Given this list of marker genes CCND2, DYNLT1, SRSF2, MTHFD2, FUS, MTCH2, FES, ZBTB32, DNAJC12, RNF144A, IFNG, ARL15, FOSL1, SLC39A14, PSMD5, CDC25A, PA2G4, KARS1, AHSA1, ACACA, GMPPB, HSPA8, PTRH2, SLC25A44, RNLS, PTPN1, IL18R1, PLVAP, ASB7, STRAP, PHLPP2, PDCL, PRF1, CFLAR, IL18RAP, PKNOX1, NOP10, GRPEL1, LIF, PDIA5, IL2RA, PRKX, TMEM70, PIM1, TRAFD1, STIP1, IRF8, PMCH, EGFL6, IGFBP7 (NCBI Gene Id 3490), SLC30A10, RRAS2, TMEM39A, CHSY1, DDX39B, SEC24D, MANF, NIPA2, ACVR1, EIF1, HDAC4, UBE2L3, EIF2B1, TOMM40, FUBP1, FURIN, SLC35F5, PFDN2, RMC1, SNCA, USP6NL (NCBI Gene Id 9712), UTP14A, TNF, B4GALT2, POLE3, SATB1, TBX21, PGS1 (NCBI Gene Id 9489), MYD88, PRNP, ATP2A2, CSRNP2, TPM4, RAB11FIP1 (RAB11 family interacting protein 1), P2RX5 (NCBI Gene Id 5026), IL15RA, CD53, VCL, GNE, GZMB, BATF, RAB29, FUBP3, SNRPG, PKM, HSPA5, NOP14, AK4, NSD3, PNO1, NUCB1, WARS1, KDSR, MTMR1, AK2, VPS37B, UCK2, MAGOHB, MMD, UBE3C, FRMD4B, ZNF207, YRDC, WDR77, PDIA6, TFG, HUNK, TMEM30B, NOP16, PTGER4, JPT2, RNF34, CSNK2A1, ANXA3, NARF, HNRNPAB, LAG3, HK1, CXCL10, DNAJB6, FKBP4, ZDHHC13, SLC35D1, PCSK5, SFPQ, MAPKAP1, ICOS, HEXA-AS1, EIF4A1, BYSL, CYTIP, STAU1, TNFSF8, PSMA5, SLC25A4, KDELR2, SLC25A32, NANS, FASLG, IFI35, FBXO4, ATP2B4, ARPC5L, CSTF2, PTGER2, IGF2R, CCT3, NABP1, SAR1A, XBP1, FUT7, EED, NACC2, MAN2A2, DCTPP1, ADAM19, COX17, IL12RB2, PSME2, MAT2A, NETO2, CXCL9, HUS1, GPR157, NUDT15 (nudix hydrolase 15), CCT7, GADD45G, LTA, BGLAP, BAK1, BPNT2, NRP1, GCH1, YAP1, MAP3K8, KIAA0040, STEAP1, CD55, SGCB, PTGES3, APOL6, NME1, RPN2, SOCS1, SLC1A5, GAR1, UBE2N, LRP8, here is a description of the gene set: studied in species Homo sapiens Genes down-regulated in CD4 T cells activated by anti-CD3 and anti-CD28: TGFB1 and IL-12 (6h) versus untreated (6h). from publication Lund R, Aittokallio T, Nevalainen O, Lahesmaa R (PMID 14607935) Human Gene Set: GSE2770_IL12_AND_TGFB_ACT_VS_ACT_CD4_TCELL_6H_DN Th1 and Th2 cells arise from a common precursor cell in response to triggering through the TCR and cytokine receptors for IL-12 or IL-4. This leads to activation of complex signaling pathways, which are not known in detail. Disturbances in the balance between type 1 and type 2 responses can lead to certain immune-mediated diseases. Thus, it is important to understand how Th1 and Th2 cells are generated. To clarify the mechanisms as to how IL-12 and IL-4 induce Th1 and Th2 differentiation and how TGF-beta can inhibit this process, we have used oligonucleotide arrays to examine the early polarization of Th1 and Th2 cells in the presence and absence of TGF-beta after 0, 2, 6 and 48 hours of polarization.